Given this list of marker genes Mkln1, Akap5 (NCBI Gene Id 70774), Abhd17b, Anp32e, Stx12, Tfrc, Myo5b, Abhd17a, Snx1, Gripap1, Rab11fip3, Zdhhc2, here is a description of the gene set: studied in species Mus musculus Mouse Gene Set: GOCC_POSTSYNAPTIC_ENDOSOME_MEMBRANE The lipid bilayer surrounding a postsynaptic endosome.